Given this list of marker genes EIF6, C8orf33, TSPAN13, HBEGF, CLEC10A, RASA4, DDHD1, GADD45G, ST8SIA4, PTGS2, SAMSN1, SPSB1, CASP1, CCNG2, RXYLT1, MAPK9, NOC4L, HSPH1, TPST1, IFI35, VWA5A, IRF1, AVL9, MRPL9, RGS11, JUNB, MED31, C6orf136, CLPP, HRH1, METTL3, STK24 (NCBI Gene Id 8428), REXO1, SNX2, OVCA2, FAM133B, SLC6A4, ARL6, PARP9, PSMD5, PTPN22 (NCBI Gene Id 5779), TACR1, AIDA, DYNLT1 (NCBI Gene Id 6993), CATSPER2, BAK1, GNPTAB, MARCHF5, TMEM33, GADD45B, RBM15, THAP4, COMTD1, FANCA, SPOP, PPIL2, MDH2, IL10, MRPL13, ALDH1A2, DDRGK1, GALNT10, FABP5, EIF1B, SLC28A2 (solute carrier family 28 member 2), NRBP1, STX3, GPBP1, GTPBP3, GFER, DNAJB4 (DnaJ heat shock protein family (Hsp40) member B4), FLAD1, IER5, TIFA, UBC, PDE10A, HRH2, PTPRT, RPF1, TRIM15, GRIN1, RNF112, STAT5A (signal transducer and activator of transcription 5A), IFNAR1, PSME1, UBE2J2, PTCD1, CD83, ZBTB18, TMEM39A, ANXA8, SLC27A1, CIB1, GDF15, PHYKPL (5-phosphohydroxy-L-lysine phospho-lyase), DUSP14, HEYL, DCAF11, RBM8A (NCBI Gene Id 9939), SGK1, RNF114 (NCBI Gene Id 55905), UBAP1, MIEN1, TLK2, POLR2G, SCFD1, SLAMF7, ZNF623, COPS4, TMEM161A, FASTKD2, HILPDA, SOX18, EMC7, HBP1, IRF8, ANAPC5, PEX13, DENND4C, HOOK2, STX12, CLP1, NFATC2IP, METTL22, OLR1, TMEM63B, RBM3, DDX54, HLA-C, RRP7A, ITPA, MED1 (mediator complex subunit 1), RABL6, SEC16B, XIRP1, NCOA3, RAB5A, PSMC4, AP3M2, SCNM1, LTO1, RBM10, PARP12, MDFIC, CTSZ, ST6GALNAC4, ODR4, CLMP, TEN1, TNRC6A (NCBI Gene Id 92763), TRIAP1, GPR12, IL7R, STAT4, LTA, TRIT1, ENPP2, ACY3, BLCAP, POM121, NINJ1, VTA1, C11orf96, CHRNA6, CEP152, F10, AKIP1, MRPL11, TM9SF4, COA3, SRD5A3, ACSM2A, SLIRP, IFT22, ARFRP1, DAXX, ATL3, CD81, PSMC6, PSMB8, GATM, ARF4, TYK2, RAB23 (RAB23, member RAS oncogene family, NCBI Gene Id 64438), USP19, C22orf39, KLHL22, PSMA5, EXOC6, HIGD1B, MB, ANPEP, ZWINT, MKNK2, PROCR, SNHG6, ENKD1, FIZ1, ATP10A, KCMF1, here is a description of the gene set: species: Homo sapiens Genes up-regulated in comparison of dendritic cells (DC) stimulated with LPS (TLR4 agonist) at 24 h versus DC cells stimulated with Pam3Csk4 (TLR1/2 agonist) at 24 h. Human Gene Set: GSE17721_LPS_VS_PAM3CSK4_24H_BMDC_UP from publication Amit I, Garber M, Chevrier N, Leite AP, Donner Y, Eisenhaure T, Guttman M, Grenier JK, Li W, Zuk O, Schubert LA, Birditt B, Shay T, Goren A, Zhang X, Smith Z, Deering R, McDonald RC, Cabili M, Bernstein BE, Rinn JL, Meissner A, Root DE, Hacohen N, Regev A (PMID 19729616) mouse primary BMDCs were stimulated with tlr ligands and gene expression changes were profiled on Affymetrix arrays